Given this list of marker genes Myoc, Spata6l, Spata6, Myo19, Cxcr4, Iqgap3, Mylk2, here is a description of the gene set: studied in species Mus musculus Mouse Gene Set: GOMF_MYOSIN_LIGHT_CHAIN_BINDING Binding to a light chain of a myosin complex.